Given this list of marker genes CMTM4, PCDH17, IQCD, TEAD1, BCL9, CDCA7L, NKX2-2, KCTD4, PCDHAC2, LMX1A, STAG2, LRGUK, LRRTM1, C6orf15 (NCBI Gene Id 29113), MAML3, TCF4, GPM6A (glycoprotein M6A), SMYD1, GDF3, NRAS, KCP, EMSY, PPP3CC, SPATA19, TGIF1, TMEM126B, TBXT, LEMD1, CACNA2D3, EGLN2, MAP2K5, GGT7, LUC7L, RASL11B, FGF16, TLX1, ZNF41, TRIM55, MAB21L2, CRABP2, PHOX2A, SLC22A2, TTC9C, MCF2, RNF181, BEST3, FOXO1, PAX7, SCNN1G, TSHZ2, SDF2L1, FEZF2, WNT3, PRDM8, PDK2, PAX6 (NCBI Gene Id 5080), PCBP4, MYL1 (NCBI Gene Id 90307), NEDD4 (NCBI Gene Id 4734), JPH1, FGF10, ELP2, EGF, LHFPL1 (NCBI Gene Id 340596), CFL2, CUEDC1, EBF1, WNT8B, CLPX, AQP6, STC2, USP32, MAP4K4, ASIC1, CDC42EP3, UCP3, LINC02880, HOXD1, LINC00649, ZIC4, HTR4, SLC39A6, DLX1, MIR9-1HG, RAB27A, PGM2L1, RGS8, HIGD1B, BCL11A, CTNNA3, ADAMTS5, HOXB4, LY6G6D, AGO2, DDR1, MYH2, CSRNP3, LRRC4, STARD3NL, ARK2N (NCBI Gene Id 147339), MBP, SMARCA1, MYO3B, NKX2-1, BCL11B, BCL2, HOXC4, MEF2C, RINT1, GPR27, KLF5, ZNF654, PDGFC, PDZK1, RGS1, NEXN-AS1, DCTN1, CRTAC1, CTCF, TPD52, IRAK1 (interleukin 1 receptor associated kinase 1), EGFR, GSK3B, CREB5, PSMA3, NR0B2, BNC2 (basonuclin zinc finger protein 2), here is a description of the gene set: Genes having at least one occurrence of the motif TYAAGTG in the regions spanning 4 kb centered on their transcription starting sites. This matches the NKX2-5 transcription factor binding site V$NKX25_01 (v7.4 TRANSFAC). species: Homo sapiens Human Gene Set: NKX25_01